Given this list of marker genes Foxf2, Cthrc1, Celsr1, Vangl2, Sec24b, Pafah1b1, here is a description of the gene set: species: Mus musculus Coordinated organization of groups of cells in the plane of an embryonic epithelium, such that they all orient to similar coordinates. Mouse Gene Set: GOBP_ESTABLISHMENT_OF_PLANAR_POLARITY_OF_EMBRYONIC_EPITHELIUM